The following is a description of a gene set: Human Gene Set: GOMF_RNA_POLYMERASE_II_CTD_HEPTAPEPTIDE_REPEAT_MODIFYING_ACTIVITY A catalytic activity that acts on the RNA polymerase II large subunit CTD heptapeptide repeat (consensus YSPTSPS). Reversible modifications cof the RNA polymerase II CTD repeats contribute to regulation of RNA polymerase activity. studied in species Homo sapiens, and this is the list of marker genes: DYRK1A, CTDP1, CDK8, BRD4, CDK9, MAPK1, SSU72L6, CDK1, CDK13, SSU72L3, SSU72L2, SSU72L4, SSU72L1, RPAP2, CDK7, CCNK, CTDSP2, CDK12, SSU72L5, CTDSP1, PPP2CA, CTDSPL, CTDSPL2, PPP1CA, SSU72